The following is a description of a gene set: Mouse Gene Set: GOBP_INTERKINETIC_NUCLEAR_MIGRATION studied in species Mus musculus The movement of the nucleus of the ventricular zone cell between the apical and the basal zone surfaces. Mitosis occurs when the nucleus is near the apical surface, that is, the lumen of the ventricle., and this is the list of marker genes: Pcm1, Hhex, Tacc2, Cep120, Pax6, Dock7, Tacc3, Kif1a, Tacc1 (transforming, acidic coiled-coil containing protein 1), Hook3